Given this list of marker genes Qng1, here is a description of the gene set: part of: tRNA processing Reactome Pathway: tRNA modification in the nucleus and cytosol This event has been computationally inferred from an event that has been demonstrated in another species.<p>The inference is based on the homology mapping from PANTHER. Briefly, reactions for which all involved PhysicalEntities (in input, output and catalyst) have a mapped orthologue/paralogue (for complexes at least 75% of components must have a mapping) are inferred to the other species. studied in species Mus musculus electronically inferred by orthology from the curated human pathway